Given this list of marker genes UCMA, CXCL12, ZNF93 (zinc finger protein 93), PDPK1, PDPR, TLN1, FSTL4, MYO15A, ZNF609, LILRB4, DNAJC6, BEND3, GLUD1, TRNP1, UBE2Z, EVC, ID4, NAV3, NDRG1, PIP5KL1, TENT2, THRB, SUPT7L (SPT7 like, STAGA complex subunit gamma), NR2F2, TDRD6, IPO9, NFASC, ILRUN, CFL1, EXOC6, MAX, OPRK1, PRKX, LCNL1, SEC24A, ESR2, RPA1, EPHB4, RAB30, ZNRF3 (NCBI Gene Id 84133), RAPGEF1, DDI2, NCALD, ADAMTS19, ETV6, AAK1, SPTBN1, NEDD9, SLX4IP, SGO1, ONECUT2, CCDC25, HSDL2, ACSL1, GABRE, SETD3, FXR1, ZNF266, TUBB4A, ARHGAP17, AGO2, TMEM199, TNRC6B, ATP6V0B, DNAL1, SLITRK3, SPIN1, DPH5 (NCBI Gene Id 51611), SAMD12, here is a description of the gene set: Genes predicted to be targets of miRBase v22 microRNA hsa-miR-4527 in miRDB v6.0 with MirTarget v4 prediction scores > 80 (high confidence targets). from publication Chen Y, Wang X (PMID 31504780) Human Gene Set: MIR4527 species: Homo sapiens